Given this list of marker genes RHBG (Rh family B glycoprotein), RHCG, SLC12A2, SLC12A5, RHCE, AQP1, RHD, AQP6, AQP8, HCN2, RHAG, here is a description of the gene set: Human Gene Set: GOBP_AMMONIUM_TRANSMEMBRANE_TRANSPORT The process in which ammonium is transported across a membrane. Ammonium is the cation NH4+. species: Homo sapiens